The following is a description of a gene set: Mouse Gene Set: GOBP_POSITIVE_REGULATION_OF_TRIGLYCERIDE_METABOLIC_PROCESS Any process that increases the frequency, rate or extent of the chemical reactions and pathways involving triglyceride, any triester of glycerol. species: Mus musculus, and this is the list of marker genes: Kat5, Gpld1, Plin5, Apoc2l, Ctdnep1, Slc27a1, Apoc3, Fgf21, Pnpla2, Scarb1, Apoc2, Rgn, Dgat1, Aadac, Ldlr, Srebf1, Gpam, Apoa5, Dgat2, Daglb, Acsl5, Nr1h3, Mfsd2a, Abhd5, Cnep1r1, Tcf7l2, Nr1h2, Apoh, Apoa4